The following is a description of a gene set: from publication Yevshin I, Sharipov R, Kolmykov S, Kondrakhin Y, Kolpakov F (PMID 30445619) Mouse Gene Set: CDYL_TARGET_GENES Genes containing one or more binding sites for (Cdyl) in their promoter regions (TSS -1000,+100 bp) as identified by GTRD version 20.06 ChIP-seq harmonization. studied in species Mus musculus, and this is the list of marker genes: Mapk8ip2, Scrt1, Gpr158, Glra1, Lhx3 (NCBI Gene Id 16871), Cacng2, Mir7b, Adgrb3, Gprin1, Pax5, Cacng3